The following is a description of a gene set: Any process that modulates the frequency, rate or extent of cell chemotaxis to fibroblast growth factor. studied in species Mus musculus Mouse Gene Set: GOBP_REGULATION_OF_CELL_CHEMOTAXIS_TO_FIBROBLAST_GROWTH_FACTOR, and this is the list of marker genes: Fgf16, Cxcl13, Fgf18, Fgf4, Fgf2, Fgf1